The following is a description of a gene set: Genes having at least one occurrence of the motif TGCNHNCWYCCYCATTAKTNNDCNMNHYCN in the regions spanning 4 kb centered on their transcription starting sites. This matches the HOXA5 transcription factor binding site V$HOX13_01 (v7.4 TRANSFAC). Human Gene Set: HOX13_01 studied in species Homo sapiens, and this is the list of marker genes: GNAI1, DPH5, TFAP2D, MIR9-1HG, OTUD7B, NTF3, FAM135B, COLEC10, FOXA1, PDE2A, CALD1, CDR2L, ZNF516-DT, CASKIN1, IGF1, PRRX1, H2AC6, UNC5B, SON, FBXO11, SMOC1, HOXB5, NDFIP1 (Nedd4 family interacting protein 1), GPR161, PPP2R2B, UBALD1, EMX2, TRPV6, HOXD4, TNRC6A, UNC5C, SVIL, FEZF2, CCND1, AMMECR1L, EHBP1, GSX1, YES1, CDK16, NEO1, ZNF485, SYNPO2L, TRIM8, LMO4, PHF21A, KCNH3